Given this list of marker genes Srp72, Brcc3, Srsf3 (serine and arginine-rich splicing factor 3), Ubl4b, Zbtb8b, Zhx1, Moap1, Degs2, Tmem170b, Marchf6, Mbnl2, Zfp964, Actr2, Srgap3, Vwc2l, Ackr4, Hnrnpa3, Kcna7, Cdk4, Mb21d2, Ephb1, Ermap, Gtf2a1, Pigk, Nsg2, Fnip1, Daam1, Kcnh1, Tnpo3, Nfatc1, Cbx7, Fxyd4, Tm9sf4, Aak1, Tars3, Phactr3, Csmd3, Smg6, Atp1b4 (NCBI Gene Id 67821), Tead2, Ripk4, Gcnt2, Fgf13, Ube2q2, Chmp1b2, Elfn2, Saraf (NCBI Gene Id 67887), Ccdc178, Epb41l1, Acsl3, Gria2, Edaradd, Atp8b1, Adarb2 (adenosine deaminase, RNA-specific, B2), Rnf150, Psg16, Cbx6, Adam9, Prex2, Col11a1 (collagen, type XI, alpha 1), Myoz3, Cmtr2, Plxna4, Nr3c1, Lamtor3 (NCBI Gene Id 99927), Sh3pxd2a, Ubn2, Ddi2, Rdm1, Vip, Mr1, Ppara, here is a description of the gene set: Mouse Gene Set: MIR_7681_5P Genes predicted to be targets of miRBase v22 microRNA mmu_miR_7681_5p in miRDB v6.0 with MirTarget v4 prediction scores > 80 (high confidence targets). studied in species Mus musculus from publication Chen Y, Wang X (PMID 31504780)